The following is a description of a gene set: The transcription factor FoxP3 partakes dominantly in the specification and function of FoxP3+ CD4+ T regulatory cells (Tregs), but is neither strictly necessary nor sufficient to determine the characteristic Treg transcriptional signature. Computational network inference and experimental testing assessed the contribution of several other transcription factors (TFs). Enforced expression of Helios or Xbp1 elicited specific signatures, but Eos, Irf4, Satb1, Lef1 and Gata1 elicited exactly the same outcome, synergizing with FoxP3 to activate most of the Treg signature, including key TFs, and enhancing FoxP3 occupancy at its genomic targets. Conversely, the Treg signature was robust to inactivation of any single cofactor. A redundant genetic switch thus locks-in the Treg phenotype, a model which accounts for several aspects of Treg physiology, differentiation and stability. Genes down-regulated in CD4 T conv over-expressing FOXP3 versus GATA1 and FOXP3. Human Gene Set: GSE40274_FOXP3_VS_FOXP3_AND_GATA1_TRANSDUCED_ACTIVATED_CD4_TCELL_DN from publication Fu W, Ergun A, Lu T, Hill JA, Haxhinasto S, Fassett MS, Gazit R, Adoro S, Glimcher L, Chan S, Kastner P, Rossi D, Collins JJ, Mathis D, Benoist C (PMID 22961053) species: Homo sapiens, and this is the list of marker genes: NICN1, LITAF, HECTD2, ADGRG3, PFKM, RASA3, TNNT2, SATB1, MYB, MARCKS, NSUN4, RALGPS1 (NCBI Gene Id 9649), SLC16A6, IFITM2, DHX58 (DExH-box helicase 58), ANO6, BCL3, IKZF4, ZMYM3, TNFRSF4, FCHSD2, RALGPS2, KCTD6, PTPRS, RNF213, IRF9, CCNJL, CCR9, IGSF3, GEMIN5, WNT3, HELZ2, TDRP, PATJ, TMEM120B, GLT8D2, TEX35, DUSP10, FXR2, ZNF354C, TTYH3, MRPL32, HOMER1, ZSCAN12, XPO6, SH3PXD2A, PTGIR, MCUB, COL15A1, PTOV1, NDRG4, EPB41L2, LRATD2, CAMK2N1, ATXN2, NR4A3, BIRC3, TCF4, AVPI1 (arginine vasopressin induced 1), TTC3, TSGA10, LRRC42, MBNL3, PRMT2, CBX2, CTSW, UBQLN4, ETS2, SLC25A23, TNFSF8, TIGD2, OASL, IFT80, PTDSS2, MX2, MOV10, ADCY6, TRAF4, LHFPL6, ENO2, DRC3, NIBAN3, IRF7, DNMT3A, GNB1L, NCF1, ZNF219, PLEKHO1 (pleckstrin homology domain containing O1), SKI, AP1M2, SPTAN1, SLC22A2, KIT, THOC7 (THO complex subunit 7), CDIP1, ARHGAP20, ARMCX1, CACNA1A, PMEPA1, HMGN3, GTF2I (NCBI Gene Id 90875), ADGRL1, HERC6, FOSL2, SH3BP5L, B4GALT3, RNF157, GREB1, KLC3, TCF7, DNAH8, FNTB, IGSF9, INSL6, FAM114A2, SIAH1, IFI44, DCAF17, LTA, INF2, TTC8, RAB3IP, AMIGO2, TUBB2A, ST8SIA1, GADD45G, ZHX2, ATP11A, ALDH18A1, TEX15, PKP4, FLJ13224, BASP1, IFIH1, SPSB1, ERF, MEX3A, KTN1, PLA2G4F, TLE1, ZNF821, RASA2, DGAT2, AGTPBP1, MMP11, TP53BP1, DDR1, SMOX, GPRASP2, ZNF362, MAP4K3, STAT5A, SLC16A3, AGO1, LETM2, WDR59, BAZ2B, PLAGL2, MAPK7, SMAD7, HEMK1, MCF2L, GNGT2, C14orf28, HLA-DMA, MARS1, SOX4, DVL2, TOM1L2, SRSF12, PURG, IMPDH2, RIMS3, ABCC1, ZUP1, DAPK1, PHLDA1, NEFL, PPP2R5D, CA8, TPCN1, ANKRD46, FMNL3, CELSR2, IFIT1B, PLSCR3, PIP4K2A, STAT5B, TULP3, MXD1, ARID5A, FHIP1B, TMIE, CACNB3, ABCG1, TG, SMIM13 (small integral membrane protein 13), IGF2R, DZIP1